Given this list of marker genes Krtap29-1, Clk3, Carmil2, Cct8, Nme2, Bbln, Krt17, Ddx60 (NCBI Gene Id 330782), Krt6a, Krt15, Gja1, Ndel1, Krt42, Hsdl1, Mmp14, Krtap15-1, Krt10 (keratin 10), Htr2a, Krtap3-3, Sestd1, Krt79, Macf1, Krt26 (keratin 26), Lmnb1, Krt90, Csnk1a1, Lmntd2, Krtap3-2 (keratin associated protein 3-2), Krt13, Krt71, Prkce, Rtn2, Krt72, Krt75, Evpl, Syce1l, Krtap5-4, Bcas3, Krt83, Krtap12-1, Krtap19-3, Krt24, Krt78, Casp14, Vmac, Krt40, Nrp1 (neuropilin 1), Syne2 (spectrin repeat containing, nuclear envelope 2), Prph, Usp10, Pja2, Krt6b, Krtap19-9b, Krt32, Dtna, Jup, Krt80, Krtap19-4, Krt20, Krtap6-2, Krt74, Phldb2, Padi6, Dsp, Krt8, Krt31, Krt77, Synm, Lmntd1, Carmil1, Ppl, Krt81, Krt84, Krtap3-1, Krt18, Nes, Ing4, Vim, Slc1a4, Krt4, Mtrr, Tlk2, Gm5478 (predicted pseudogene 5478), Krtap5-3, Krtap14, Krtap4-6, Cldn11, Krt12 (NCBI Gene Id 268482), Adora2a, Krtap6-5, Des, Dst, Psmd10, Krt36, Krt85, Krtap16-1, Rad51, Krt7, Hspa8, Mns1 (meiosis-specific nuclear structural protein 1), Gper1, Krt25, Stn1, Krt16, Krt35, Krt222, Krt9, Krt1, Krt82, Slc1a6, Krt19, Krt86, Nol9, Krtap19-5, Krt28, Eif6, Gfap, Krtap26-1 (NCBI Gene Id 69533), Hoxa13, Upp2, Sap30bp, Krt27, Ndor1, Krt33a, Bfsp2, Nefl, Krt76, Krt73, Nefh, Krtap16-3, Krt34, Krtap21-1, Shank2, Nme1, Dmd, Krtap9-3, Exd2, Krtap5-2, Krtap5-5, Krtap8-1, Ina, Disc1, Ldlrap1, Iffo2, Pkp2, Pfdn5, Lmna, Mdn1, Krt5, Krt33b, Sync (syncoilin), Krt14, Nr1i2, Pkn2, Bfsp1, Fam83h, Krt39, Iffo1, Krtap19-2, Eppk1, Krtap5-1, Plec, Lmnb2, Narf, Krtap19-1, Tchp, Gm5414, Smarca2, Krt2 (NCBI Gene Id 208726), Zfp131, Nefm, S100a8, Krt87, Pcp4, Myo5a, Fbf1, Gsn, Krt23, Krtap7-1, Dyrk1a, here is a description of the gene set: Cytoskeletal structure made from intermediate filaments, typically organized in the cytosol as an extended system that stretches from the nuclear envelope to the plasma membrane. Some intermediate filaments run parallel to the cell surface, while others traverse the cytosol; together they form an internal framework that helps support the shape and resilience of the cell. species: Mus musculus Mouse Gene Set: GOCC_INTERMEDIATE_FILAMENT_CYTOSKELETON